Given this list of marker genes Scfd1, Neurod2, Emc3, Ncam1 (neural cell adhesion molecule 1), Cd33, Agfg2, Bmp7, Capn6, Otud4, here is a description of the gene set: species: Mus musculus Genes predicted to be targets of miRBase v22 microRNA mmu_miR_466f in miRDB v6.0 with MirTarget v4 prediction scores > 80 (high confidence targets). Mouse Gene Set: MIR_466F from publication Chen Y, Wang X (PMID 31504780)